Given this list of marker genes IL6, LIMCH1, OR4D6, VWDE, COL3A1, OCA2 (OCA2 melanosomal transmembrane protein), CALD1, TNIK, FAM47C, CCDC141, TYR, PLPPR4 (NCBI Gene Id 9890), TMOD2, SSX7, ENDOD1, CEP126, FZD8, USP51, SERPINB13, PDZD2, GSDMC, ITIH5, KDM4D, RNASE1, TCF3, DLC1 (NCBI Gene Id 94517), SCN11A, GNPDA2, HOMER1 (NCBI Gene Id 9456), FUT8, CACNB2, TMEM71, GPRIN3, MIR17HG, SYT14, DEFB126, PRKD1, COL19A1, CLEC12A, CMKLR2, AKT3, MCOLN3, HSPB3, PKHD1L1, IPCEF1, HAVCR2 (hepatitis A virus cellular receptor 2), SELP, MAGEB4, XAGE2, RNASE9 (NCBI Gene Id 390443), GSDME, PES1, ENTREP1, MARK1, TANC2, OR2H1, ZNF471, ANGPTL5, HSBP1, DOCK8, C9, TMEM144, STEAP4, AGTR2, TMEM243 (NCBI Gene Id 79161), RNASE6, LINC00305, ADGRF2P, MAGEA2B, SPP2, SATB1, SLC16A9, TMSB15A, STK26, YTHDC1, KIF5C, GAPT, CTNNA3, F11, KIAA1217, IL1RL1, LCA5, PTPRR, RPL35P1, MAST4, MGP, ADGRF4, CXCL1, CHRM3, CSRNP3, CYTIP, PTEN, PRNP, AWAT2, HSPD1, ELMOD1, MAGEB2, HAUS5, IFNL1, BMPR1B, THEMIS, POU6F2, LPAR3, DYNC2H1, SV2C (synaptic vesicle glycoprotein 2C), MBOAT2, DCDC1, PRMT2, PPP1R42, PELI2, GLRB, NOP10, PDE6H, SMAD9, RTL5, TTN, PTENP1, COL1A2, KCNK2, CRISP3, OR2T27, RTL9 (retrotransposon Gag like 9), TOX, DCUN1D5, MAGEB3 (MAGE family member B3), GUCY2C, PRIM2, ZBTB46, ENTHD1, HTR7, ENPP6, TLR8, SEMA3C, MARCO, EDDM3A, RBPMS, ANGEL1, ST18 (NCBI Gene Id 9705), SDK1, COLEC12, ZNF827, CLCA1, FAM9A, SPRED1, FMN2, PRKY, GMPR, ZNF311, OR10A7, AGR2, GCG, NAV3, PAM, LMO2, MGA, MAGEA9 (NCBI Gene Id 4108), KLRK1, ADGRF1, CCR9, PLA2G2A, PRTG, PRKACG, INSL5, GRM8, IFNA1, OPHN1, LINC02210, IGSF1, ZNF624, SEMA6D, LYSMD2, SDHAF3 (NCBI Gene Id 57001), CREB5, KLRC4, SLC1A3, SYCP2L, C3orf52, QSOX1, SPMIP4, MAGEH1, BICD1, PWWP3B, MPP1, PNLIP, DNASE2B, IL6-AS1, EDDM3B, SLC35F2, UBE2G2, BTC, PIK3CG, IFNA6, PBX1 (NCBI Gene Id 5087), EZHIP, GSPT2, PRKAR2B, PRKCQ, MAGEB1, MLLT3, TINAG, PLBD1, CDH12, ARHGDIB, PALLD, DEFB129, GPBP1L1, DSC3, GABARAPL2, LHFPL1, GDF3, SSBP2, C1GALT1C1, CCDC172, C6orf141, TLR2, B3GALT5, NCALD, LRRC8C, MMP8, SMIM3, ESRP1, TMPRSS11E, SERPINB2 (serpin family B member 2), AIM2, KLHL41, SPACA7, CR1L, CHST2, MCU, YBX3 (Y-box binding protein 3), OSBPL10, CSAG4, OAT, SERPINB12 (NCBI Gene Id 89777), TMPRSS11B, TBC1D30, SLC12A6, SCIN, FRAS1, XAGE5, OR2T35, CLEC7A, TOMM7, NTF3, GADL1, MTX3, MAGEA2, WDR64, CPB1, OSMR, SERPINB11, SPIRE1, CRISP2, SULF1, TENM3, ADGRV1, MIR99AHG, AREG, PDE1A (NCBI Gene Id 5136), TSGA13, GUCY1A1, MMP27, RHAG, SCAND3, IFNA13, FZD1, ARHGAP10, CYP2E1, CSAG3, CELF2-AS1, LRCH2, NFIB, GPR119, IKZF1, HSFX1, TMPRSS7, HECW2, NUTM1 (NUT midline carcinoma family member 1), CSTF2, PLSCR2, MACROH2A2, PSME3IP1, KL, MSRB3, SRI, CRB1, ADGRF5 (NCBI Gene Id 23282), PRPS1L1, MAGED1, POU2AF2, here is a description of the gene set: species: Homo sapiens from publication Acevedo LG, Bieda M, Green R, Farnham PJ (PMID 18413731) Human Gene Set: ACEVEDO_LIVER_CANCER_WITH_H3K27ME3_UP Genes whose promoters display higher levels of histone H3 trimethylation mark at K27 (H3K27me3) in hepatocellular carcinoma (HCC) compared to normal liver. There is widespread interest in efficient characterization of differences between tumor and normal samples. Here, we show an effective methodology for genome-scale characterization of tumors. Using matched normal and tumor samples from liver cancer patients, as well as non-cancer-related normal liver tissue, we first determined changes in gene expression as monitored on RNA expression arrays. We identified several hundred mRNAs that were consistently changed in the tumor samples. To characterize the mechanisms responsible for creation of the tumor-specific transcriptome, we performed chromatin immunoprecipitation on microarray experiments to assay binding of RNA polymerase II, H3me3K27, and H3me3K9 and DNA methylation in 25,000 promoter regions. These experiments identified changes in active and silenced regions of the genome in the tumor cells. Finally, we used a virtual comparative genomic hybridization method to identify copy number alterations in the tumor samples. Through comparison of RNA polymerase II binding, chromatin structure, DNA methylation, and copy number changes, we suggest that the major contributor to creation of the liver tumor transcriptome was changes in gene copy number.